Given this list of marker genes Atp4a, Atp6ap2, Clic4, Slc9a1, Aqp11, Slc9a9 (NCBI Gene Id 70648), Slamf8, Atp4b, Car14, Slc12a5, Atp6v0a1 (ATPase, H+ transporting, lysosomal V0 subunit A1), Slc9a8, Grn, Bcl2, Atp1a4, Avpr1a, Cln5, Snapin, Ube3a, Ppt1, Avp, Slc26a9, Slc4a9, Rab39, Slc9a5, Slc9c1, Slc4a10, Hvcn1, Ttpa, Atp6v1b2, Car2, Agtr1a, Slc26a4, Slc26a6, Clcnkb, Tmem175, Rhcg, Lrrk2, Ednrb, Tmem165, Rnasek, Mafg, Gpr39, Pdk4, Tmem106b, Rogdi, Lacc1, Cln6, Atp12a, Slc4a4, Chp1, Slc9a4, Slc9a6, Lamp2, Slc11a1, Cftr, Lamp1, Tmem199, Creg1, Slc4a8, Dmxl1, Wdr72, Atp6ap1, Slc9a7, Slc26a3, Atp6ap1l, Pdk2 (pyruvate dehydrogenase kinase, isoenzyme 2), Car7, Dmxl2, Vps33a, Slc9a3, Mapk3, Fasl, Slc9b1, Atp6v1b1, Tm9sf4, Atp6v0a2, Rab7, Tpcn2, Slc4a7, Mapk1, Car12, Trp53, Cln3, Rab20, Atp6v0a4, Oca2, Slc45a2, Edn1, Slc4a1, Ccdc115, Slc4a2, Atp5f1b, Atp6v0d1, Slc4a5, Spns1, Tmem9 (transmembrane protein 9), Tcirg1, Slc4a3, Atp6v0c, Chp2, Rab38, Atp6v0d2, Slc9a2, Cckbr, Car4, Gpr89, Tasl, Kcnj16, here is a description of the gene set: Mouse Gene Set: GOBP_REGULATION_OF_PH species: Mus musculus Any process involved in the maintenance of an internal equilibrium of hydrogen ions, thereby modulating the internal pH, within an organism or cell.